The following is a description of a gene set: studied in species Homo sapiens Human Gene Set: GOBP_L_TRYPTOPHAN_CATABOLIC_PROCESS_TO_KYNURENINE The chemical reactions and pathways resulting in the breakdown of L-tryptophan into other compounds, including kynurenine., and this is the list of marker genes: AFMID, IDO2, KYNU, TDO2, IDO1